Given this list of marker genes GZMB, EEF2 (eukaryotic translation elongation factor 2), DDR1, SERPINB9, ISG15, UBAP2L, RPL10A, MTHFD2, BATF3, JUND, HMGB3, ATF4, CD7, EIF1B, CASP1, TUBB2A, NABP1, DNAJA1, IARS1, RPL3, CDH15, IMP3, SLC7A5, TOX4, WDR83OS, ALDH18A1, EIF4EBP1, TMOD3, BAG3, NORAD, H2AX, SLC1A4, BANF1, HERPUD1, NAA38, H2AC4, SNHG6, here is a description of the gene set: During the safety evaluation process of new drugs and chemicals, a battery of genotoxicity tests is conducted starting with in vitro genotoxicity assays. Obtaining positive results in in vitro genotoxicity tests is not uncommon. Follow-up studies to determine the biological relevance of positive genotoxicity results are costly, time consuming, and utilize animals. More efficient methods, especially for identifying a putative mode of action like an indirect mechanism of genotoxicity (where DNA molecules are not the initial primary targets), would greatly improve the risk assessment for genotoxins. To this end, we are participating in an International Life Sciences Institute (ILSI) project involving studies of gene expression changes caused by model genotoxins. The purpose of the work is to evaluate gene expression tools in general, and specifically for discriminating genotoxins that are direct-acting from indirect-acting. Our lab has evaluated gene expression changes as well as micronuclei (MN) in L5178Y TK(+/-) mouse lymphoma cells treated with six compounds. Direct-acting genotoxins (where DNA is the initial primary target) that were evaluated included the DNA crosslinking agents, mitomycin C (MMC) and cisplatin (CIS), and an alkylating agent, methyl methanesulfonate (MMS). Indirect-acting genotoxins included hydroxyurea (HU), a ribonucleotide reductase inhibitor, taxol (TXL), a microtubule inhibitor, and etoposide (ETOP), a DNA topoisomerase II inhibitor. Microarray gene expression analysis was conducted using Affymetrix mouse oligonucleotide arrays on RNA samples derived from cells which were harvested immediately after the 4 h chemical treatment, and 20 h after the 4 h chemical treatment. The evaluation of these experimental results yields evidence of differentially regulated genes at both 4 and 24 h time points that appear to have discriminating power for direct versus indirect genotoxins, and therefore may serve as a fingerprint for classifying chemicals when their mechanism of action is unknown. Human Gene Set: HU_GENOTOXIC_DAMAGE_24HR Genes most consistently regulated at 24 h by all six genotoxins tested: cisplatin, methyl methanesulfonate, mitomycin C, taxol, hydroxyurea and etoposide. species: Mus musculus from publication Hu T, Gibson DP, Carr GJ, Torontali SM, Tiesman JP, Chaney JG, Aardema MJ (PMID 15120960)